Given this list of marker genes PRKAA2, STK3, TEAD1, PRKAG3, STK4, PRKAG2, TEAD4, RHOD, RHO, PRKAB2 (protein kinase AMP-activated non-catalytic subunit beta 2), PRKAA1, LATS2, MOB1A, TEAD2, RHOA, PRKAG1, RHOC, PRKAB1, LATS1, HMGCR, CCN1, TEAD3, YAP1, RHOB, CCN2, SAV1, here is a description of the gene set: species: Homo sapiens Human Gene Set: WP_TARGETING_YAP_IN_PANCREATIC_DUCTAL_ADENOCARCINOMA_PDAC Targeting YAP in pancreatic ductal adenocarcinoma (PDAC)